Given this list of marker genes CRLF3, RNF2, RAF1, MAP3K13, LAMP3, GPR37, RAB5A, PTPN11, NHERF1, BAP1, PPP1R2, STARD3, ST7, ANGEL2, E2F6, SOS1, ZBTB1, DTNB, GP1BB, PDLIM3, CAMSAP1, DDX10, INPP5F, SFMBT1, EPHA2, NUS1P3, NXT2, REL, NUP153, ARFIP2, PPFIA1, WHAMM, PRKCD, ABCB1, IL27RA (interleukin 27 receptor subunit alpha), SRSF10, MAT2A, PTHLH, FXR2, IFI44 (interferon induced protein 44), IFI6, RMND5A, RUNX3, IFNA5, SAP30, CREM, NACAD, PAK3, LZTS3, NECAP1, LIN37, RFXAP, DLG1, TFRC, VLDLR, DLG3, RNF19B, RAP2A, PGM3, ZNF273, KCNK1, CDKL5, ARL4A, TESK2, SLC25A13, PTS, E2F5, SETD2, SLC7A1 (NCBI Gene Id 6541), WDR82, CLCN5, PRPF19, IFNGR1, POP7, ANKRD40, SLC16A1, DUSP7, USP6NL, SLC15A2, NR2C2, HSPA4L, LYN, HLTF, EED, AKAP8L, OLFM1, PLS1, TTBK2, PDE4D, ACSM3, PAQR3, SLC30A4, FKBP5, CHD1, ZNF593, ADAMTS3, TUBGCP4, ZFY, BPGM, ALDH3B2, MAOA, STBD1, TMF1 (NCBI Gene Id 7110), CDC6, SIKE1, CTSV, TEX30, TCHH, BTRC, FUBP1, PIP5K1A, THAP11, IGSF3, ZNF131, PRKD3, TRAF3, PRPF4, PRKACA, YAF2, ATP7B, HLA-DPB1, DFFB, PTGER2, ARFGEF2, BLMH, ZBTB33, SSR1, ARHGEF5 (NCBI Gene Id 7984), N4BP2L1, TTF1, ZNF45, STIL, INA, NPTX2, SUZ12, DDX21, BMP2 (NCBI Gene Id 650), SEC23IP, PTPN21, POLR2H, DHX8, YKT6, CCNC, PLSCR1, CDC40, TAF13, IREB2, GABRE, TRIM52, KPNA6, PLAAT4, FAM169A, RGS3, KCNH2, KPNA5, B3GALT5, PLEKHB2, NAT1, GK, SNRK, RFK, VEGFA, H2AC18, ATRN, MLF1, EXPH5, WDR47, RNF40, DYNC1I1 (NCBI Gene Id 1780), MOAP1, GATM, SMG1, ABHD3, DR1, PCGF3, PPP2R5B, BRAF, CLPX (caseinolytic mitochondrial matrix peptidase chaperone subunit X), POU2F1, FAM234B, TBC1D12, SOCS2, GNA13, HSPA12A, ZNF37A, MED6, THAP12, BTG3, HSPA2, MPHOSPH8, SLC6A8, PTPRE, GTF2B, RAD51C, TRIM33, CYRIA, ETFDH, GPX3, KLHL23, SON, RORA, DNAJC24 (DnaJ heat shock protein family (Hsp40) member C24), B3GALNT1, ENO2, ZBTB6, NR4A3, GNL2, ALKBH1, PALS2, RND2, NFE2L3, DOHH, TMEM268, CDC5L, ISL1, BAK1, ARK2N, PLCL1, NEFM (neurofilament medium chain), KHDRBS3, PARM1, DCAF7, RRP12, here is a description of the gene set: from publication Browne EP, Wing B, Coleman D, Shenk T (PMID 11711622) studied in species Homo sapiens Genes up-regulated in primary fibroblast cell culture after infection with HCMV (AD169 strain) at 16 h time point that were not up-regulated at the previous time point, 14 h. Human Gene Set: BROWNE_HCMV_INFECTION_16HR_UP The effect of human cytomegalovirus (HCMV) infection on cellular mRNA accumulation was analyzed by gene chip technology. During a 48-h time course after infection of human diploid fibroblasts, 1,425 cellular mRNAs were found to be up-regulated or down-regulated by threefold or greater in at least two consecutive time points. Several classes of genes were prominently affected, including interferon response genes, cell cycle regulators, apoptosis regulators, inflammatory pathway genes, and immune regulators. The number of mRNAs that were up-regulated or down-regulated were roughly equal over the complete time course. However, for the first 8 h after infection, the number of up-regulated mRNAs was significantly less than the number of down-regulated mRNAs. By analyzing the mRNA expression profile of cells infected in the presence of cycloheximide, it was found that a minimum of 25 mRNAs were modulated by HCMV in the absence of protein synthesis. These included mRNAs encoded by a small number of interferon-responsive genes, as well as beta interferon itself. Cellular mRNA levels in cytomegalovirus-infected cells were compared to the levels in cells infected with UV-inactivated virus. The inactivated virus caused the up-regulation of a much greater number of mRNAs, many of which encoded proteins with antiviral roles, such as interferon-responsive genes and proinflammatory cytokines. These data argue that one or more newly synthesized viral gene products block the induction of antiviral pathways that are triggered by HCMV binding and entry.